Given this list of marker genes ITGAM, SLC30A8, SH3GLB1, NNAT, TPR, GPLD1, GIPR, CDK5R1, GIP, ATP2C1, COMMD1, CEMIP, TMEM30A, TGFB3, PRKN, PRKCA (protein kinase C alpha), IL1B, TARDBP, HUWE1 (NCBI Gene Id 54789), TMEM97, TGFB1, AKAP5, CASR, LEP, GHRL, ARF6, ACHE, TM9SF4, AKT2, UBE2D3, MCU, MIEF2, FUT10, FLNA, EP300, MLXIPL, PSMD9, PIK3R2, TSG101, STX4, BAP1, F2RL2, MYO1C, FBXW7, HPS4, BAD, TOMM7, ARHGEF5, TNF, FUT11, UBE2L3, RAPGEF3, HRAS, ABCG1, SLC2A2, APBB1, NMT1, GPER1, ERBB2, FGG, KCNN4, PLCB1, FFAR2, ZPR1, TENM1, HSPA1L, CORO2B, SREBF2, ISL1, SFN, F2, CIB1, CHRM3, CEP135, PSEN1, ANXA13, CRH (NCBI Gene Id 1392), ANKRD1, TRIM28, GLI3, TUNAR, TRPM4, NLGN2, PLA2G1B, MAVS (mitochondrial antiviral signaling protein), FGA, LEPROT, PRKCD, C1QTNF12, IER3IP1, CDK1, PTPN23, VPS28, NR1H4, SMO (NCBI Gene Id 6608), SHH, RAB29, UBE2J2, IGF1, PHPT1, PTP4A3, IPO5, CCT6A, APOE, BBC3, YWHAE, PLK3, RFX6, RAC1, DMAP1, VEGFC, RIPOR1, PRKCB, APBB3, OSBP, NKX6-1, GPRC6A, MAPK14, EFCAB7, PRR5L, ATG13 (autophagy related 13), SYBU, GOLPH3, FGB, HLA-DRB1, PRKCE, ADAM8, HPCA, CEP295, TRH, PRKACA, ERGIC3, SIRT3, WLS, APP, TCAF1, PLA2G6, ACSL4, ADCY8, PIK3R1, MTCL1, SMAD3, ADCY10 (NCBI Gene Id 82259), CSNK2A2, TCAF2, SYTL4 (NCBI Gene Id 94121), P2RX7, BLK, DYNLL1, HIF1A, CHRM1, RAC2, OAZ1, B3GAT3, PPIA, OAZ2, PCK2, TCP1, PCNT, XPO4, EMD, ITGB2, HCAR2, TLR4, OR51E2, FFAR1, TCF7L2, SLC51B, SEC16B, DNM1L, OAZ3, HYAL2, PDX1, ORAI1, ANO1, PPARG, PPARD, ANP32B, IRS2, CAMK1, PRNP, MDM2, CDH1, CLN3, TM7SF3, ITGB1BP1, ITPR1, BCAP31, GNA11, NR1H2, MYH10, PRP4K, CEP290, ABCC8, SOX4, SORL1, ARIH2, GOLPH3L, NMU, JAK2, ACSL3, GPR27, ICE1, USP36, MIR199B, RNF31, C1QTNF3, BAG3, MYRIP, CD81, IL1A, TOMM70, CD38, GCG, TTN, MYO18A, ADAM9, GPR68, SERP1, TMEM132A, MICALL2, ABAT, UCN3, PFKFB2, FYN, VPS11, C2CD2L, CEP131, ZC3H12A, EXPH5, ZIC1, HSP90AA1, ADORA2A, GLUD1, LRRC8A, PPM1A, IL13, HTRA2, WRAP53, ATP13A2, HCLS1 (hematopoietic cell-specific Lyn substrate 1), SIRT6, TMED10, KCNB1, FZD5, GSK3B, VPS35 (NCBI Gene Id 91808), CHP1, CDK5, RHOU, TGFB2, DOC2B, CHP2, RUFY3, EDEM1, SEC24A, CTDSPL2, PARD6A, CENPJ, ZDHHC2, NR0B2, RPH3AL, OXCT1, MAPK8, CRYZL2P-SEC16B, GSK3A, UBL5, RAN, CD2AP, RACK1, TRPA1, PDZK1, KIF20B, NADK, UBL4B, AACS, PINK1, GAS6, STOM (stomatin), XBP1 (X-box binding protein 1), ANK3, CNST, F2RL1, TMEM30B, UBR5, ABLIM3, RBP4, CFTR, PAK1, JUP, PGRMC1, ECT2, PRKAR1A, BSG, ASPH, NPEPPS, MPC2, VSNL1, RAPGEF4, PRKD1, CD33, EDEM2, ANG, TREM2, PDCD10, GZMB, BAIAP3, INS, SLC35D3, HDAC3, CEP120, RBM22, VAMP2, BMP6, PCM1, PPP3CB, SAE1, GCK, PRKAA1, C2CD5, MIEF1, IFNG, TRPM5, ZFAND1, TLR2, FRMD4A, CAPN10, MYOM1, PPID, PFKM, UNC13B (unc-13 homolog B), here is a description of the gene set: species: Homo sapiens Any process that activates or increases the frequency, rate or extent of establishment of protein localization. Human Gene Set: GOBP_POSITIVE_REGULATION_OF_ESTABLISHMENT_OF_PROTEIN_LOCALIZATION